Given this list of marker genes NAB1, CREB1, DUSP7 (dual specificity phosphatase 7), TPH1, MEF2A, RRAD, SH3GL3, PPP2CA, FOS, DUSP6, CDK5, ID4, MAPK7, F3, DUSP4, RPS6KA3, PPP2R5D, MAPKAPK2, MAPK14, MEF2C, MEF2D, ELK1, RPS6KA2, SRF, EP300, TCF12, ASCL1, ATF2, EGR2, PPP2CB, EGR4, CHD4, MAPK1, MAPK11, JUND, RPS6KA1, DNM2, ATF1, DUSP3, VGF, MAPK3, LYL1, CDK5R1, ID2, ID1, CDK5R2, PPP2R1B, EGR3, VRK3, TRIB1, SGK1, REST, PPP2R1A, NAB2, ID3, JUNB, RPS6KA5, FOSB, EGR1, FOSL1, ARC, here is a description of the gene set: part of: Signaling by NTRK1 (TRKA) An important function of the kinase cascade triggered by neurotrophins is to induce the phosphorylation and activation of transcription factors in the nucleus to initiate new programs of gene expression. Transcription factors directly activated by neurotrophin signalling are responsible for induction of immediate-early genes, many of which are transcription factors. These in turn are involved in the induction of delayed-early genes. species: Homo sapiens Reactome Pathway: Nuclear Events (kinase and transcription factor activation)